Given this list of marker genes SLC39A7, HEPH, SLC39A14, SLC39A2, SLC39A6, SLC39A8, CP, SLC30A1, SLC30A2, SLC40A1, SLC11A1, SLC39A1, SLC31A1, SLC39A5, SLC41A1, SLC39A10, SLC30A8, SLC39A4, SLC11A2, SLC39A3, SLC30A10, SLC30A3, SLC30A5, SLC41A2, here is a description of the gene set: studied in species Homo sapiens Metal ion SLC transporters Human Gene Set: REACTOME_METAL_ION_SLC_TRANSPORTERS